The following is a description of a gene set: part of: Platelet homeostasis Reactome Pathway: Platelet sensitization by LDL Physiological concentrations (1g/L) of Low density lipoprotein (LDL) enhance platelet aggregation responses initiated by thrombin, collagen, and ADP. This enhancement involves the rapid phosphorylation of p38 mitogen-activated protein kinase (p38MAPK) at Thr180 and Tyr182. The receptor for LDL is ApoER2, a splice variant of the classical ApoE receptor. ApoER2 stimulation leads to association of the Src family kinase Fgr which is probably responsible for subsequent phosphorylation of p38MAPK. This stimulation is transient because LDL also increases the activity of PECAM-1, which stimulates phosphatases that dephosphorylate p38MAPK. species: Homo sapiens, and this is the list of marker genes: PLA2G4A, PTPN11, PPP2CA, PECAM1, PPP2R5B, PPP2CB, LRP8, FGR (FGR proto-oncogene, Src family tyrosine kinase), PTPN6 (NCBI Gene Id 5777), PPP2R1B, APOB, PPP2R5A, PPP2R1A, MAPK14, PPP2R5D, PPP2R5E, PPP2R5C